The following is a description of a gene set: The lipid bilayer surrounding a secretory granule. Human Gene Set: GOCC_SECRETORY_GRANULE_MEMBRANE species: Homo sapiens, and this is the list of marker genes: SPACA6, LAMTOR1, CEACAM6, GP2, RAB26, CD93, CLCA1, MCEMP1, EQTN, DDOST, MOSPD2, CLEC4C, ATP6V0C, SIRPB1, LAIR1, SLC11A1, IZUMO1, HYAL3, ATP11B, RAB9B, CXCR2, ABCC4, SLC2A3, RAB14 (RAB14, member RAS oncogene family), TRIP11, ANXA4, SPACA3, TICAM2, SYNGR1 (synaptogyrin 1), NDUFC2, MOXD1, ATP6V1D (NCBI Gene Id 51382), ATP8B4, RAB4B, ATP6AP2, STING1, TEX101, RAB5C, CYBB, MGAM, SRI, FCER1G, LAMP3, RHOA, RAB24, FCAR, PIGR, HVCN1, SELP, KIF1A, ANPEP, VAMP7, CPNE3, CFAP65, CD68 (NCBI Gene Id 968), DEGS1, NFASC, LAMP1, CYSTM1, DYNLL1, NFAM1, PLA1A, CD47, PKP1, VAMP8, ITGAM, PCDH7, UBR4, CLEC4D (C-type lectin domain family 4 member D), RAP1A, SNAP25, PNLIPRP2, ZG16, PSEN1, MAGT1, CYBA, NBEAL2, SYT5, LILRB3, CD300A, ADGRG3, AP1M1, SPACA1, OLR1, FPR1 (NCBI Gene Id 2357), CD109, ITGAV, TOM1, SLC30A2, PTPRN2, RAB18 (RAB18, member RAS oncogene family), MLEC, GLIPR1, ADGRE3, ITPR3, STX3, P2RX1, SYTL4, DMBT1, RHOF, RAB7A, FABP5 (fatty acid binding protein 5), PRCP, DCST2, ITPR2, DIAPH1, TMEM63B, SYT4, SLC18A2, CAV1, PLD1, TMC6, CLEC5A, COPB1, TMEM184A (transmembrane protein 184A), PTPRJ, AP2A2, DNAJC13, CD58 (NCBI Gene Id 965), TMBIM1, DYNC1LI1, B4GALT1, USP8, MS4A3 (NCBI Gene Id 95934), PCSK4, TARM1, SCG3, TMED10, SYT1 (NCBI Gene Id 6857), RAB3D, ADAM8, HLA-H, ATP8A1, LILRB2, RAB37, NCSTN (NCBI Gene Id 57297), GPR84, TNFRSF1B, LPCAT1, HLA-C, IQGAP2, SURF4, VPS35L, RAB31, RAC1, BST1, CPNE1, SNAP23, DNAJC5, RND2, TMEM225, PSAP, SLC18B1, PLAUR, SLC27A2, STOM, ATP8B3, CHRNB4, ITPR1, ZPBP, TMX3, ABCA3, AGPAT2, PLAU, CR1, MFGE8, DCST1 (NCBI Gene Id 149095), SIGLEC14, SYT2, VPS13C, ICA1, SERPINB6, TCIRG1, HMOX2, PTPRC, SERPINA5, SLC15A4, LGALS3, VNN1, CD55, SERPINB12, ANO6 (NCBI Gene Id 196527), NCKAP1L, SCAMP1, FRMPD3, ITGB3, DBH, CYB561, LAMTOR2, BST2, MMP25, CUZD1 (CUB and zona pellucida like domains 1), ABCA12, RHOG, VPS13B, SYCN, RAB5B, FCGR2A, LILRA3, CD36, CD9, SVIP, LAMTOR3, DSG1, SLC17A9, TMEM30A, LAMP2, STK10, RAP2B, RAP1B, CMTM6, DSP (desmoplakin), ATP11A, CPE, SLC44A2, AZU1, TLR2, STXBP2, SLC30A8, KCNAB2, SNAP29, CEACAM8, VAMP1, ARL8A, TMED2, TMEM63A, CD14, ITGB2, ANXA7, TBC1D10C, RAB6A, BRI3, TEKT3 (tektin 3), APLP2, ITGAX, FCGR3B, MANBA, TSPAN14, SIRPA, CCDC136, FAM170B, CADPS, SLC30A5, IQGAP1, IRAG2, PGRMC1, DOK3, SPACA4, HLA-B (major histocompatibility complex, class I, B, NCBI Gene Id 730410), ITGA2B, ALDH3B1, SLC2A5 (solute carrier family 2 member 5), RAB3A, MOXD2P, SIGLEC5, PHACTR2, ITGAL, PAM, DGAT1, LY6G6F, EXOC3, PTAFR, CAV2, SELL, ACP3, TYROBP, VAPA, ATAD3B, STBD1, SNCA, NRAS, VAMP2, SLC9A4 (solute carrier family 9 member A4), RAB44, GAA, CEACAM1, ORMDL3, TMEM95, C3AR1, RAB10, CEACAM3, CYB5R1, SPARC, SLCO4C1, SIGLEC9, CD33, CD177, LHFPL2, CD59, FPR2, STXBP5, ACRBP, CXCR1, IZUMO3, C5AR1, PTPRB, CLEC12A, PECAM1, DSC1, MME (membrane metalloendopeptidase), IGF2R, RAP2C, SERPINB10, CD63 (CD63 molecule), SLC18A1, TMEM179B, ADAM10, PKDREJ, ATP6V0A1, ABCA13, TRPM2, RAB27B, CA4, TMEM190, CD53, ENPP4, CD46, HGSNAT, ADGRE5, FLOT2, BSG, CD44, CKAP4, MGST1 (NCBI Gene Id 4257)